Given this list of marker genes MYH11, FH, ACADVL, PIGY, DEF6, FCN3, here is a description of the gene set: Inflammation of the intestine leading to bacterial invasion causing cellular damage and death which causes necrosis of the colon and intestine. Human Gene Set: HP_NECROTIZING_ENTEROCOLITIS studied in species Homo sapiens Necrotizing enterocolitis